Given this list of marker genes DEDD, MYH10, RGR, MLN, SFRP4, FERMT2, POLR3F, CAMK2G, ZNF592, ZNF132, ZNF208, HES2, BBIP1, H1-4, ADAM12, SPAM1, HABP4, ERICH1, H6PD, IL18RAP, AOC2, SOX9, CASP2, MYL5, SELP, LPAL2, HSD17B3, VPS9D1, HPD, MIA, C4BPA, SERPINB13, DNAH17, ADCY2, GPX3, JRK, LTBP4 (latent transforming growth factor beta binding protein 4), OPRPN (opiorphin prepropeptide), LMO2, CHRNE, PXN, LGALS9, POLR3D, OLR1, NR1I2, REG1B, PTGIS, SNAP91 (NCBI Gene Id 9892), CTSA, C9, RNF126, CDK18, SLC1A2, HIPK2, PLA2G4C, PXDN, OCEL1 (NCBI Gene Id 79629), VSTM4 (NCBI Gene Id 196740), GK2, TRIM21, AGRP, KLKB1, AVPR1A, MINAR1, CLCN5, KCNMB1, SGK1, FCN2, FOXO4, TWF1, IFNA2, ZBTB39, N4BP2L2-IT2 (N4BPL2 intronic transcript 2, NCBI Gene Id 116828), MLF1, IRF7, RPE, EPYC, PLPP3, ABCC9, TESK1, CTSO, CRADD, SCGN, SHROOM2, MYO6, PLAAT4, GREB1, PTPRT, GAS2L1, TAF6L (TATA-box binding protein associated factor 6 like), IVL, CCR2, GPM6B, ERN1 (NCBI Gene Id 63433), HR, NTRK3, AKR1D1, GRM3, G6PC1, IFI30, MYEF2, SLC10A2, RS1, GRK1, TNKS, PPFIBP2, PDPK1, DLEC1, PC, KLK8, BRINP3 (BMP/retinoic acid inducible neural specific 3), KRT1, PTH, PXDC1, MAN1A1, CHD2, MUC1, GFPT2, ZNF24, SIN3B, HDAC9, P2RX3, HAAO, PFKFB2, PCSK2, PYGM, ONECUT1, HLA-DQB1, LMO4, GDF5, FZD9, PKP2, ERVW-1, IFIT1, TSC22D1, AMIGO2, TNP2, HLA-DRB6, KCNAB1, NFKBIL1, TCL1A, CYP3A5, MUC7, ZFHX3, CCIN, SPOCK1, FAM161A, SLC1A7, PDE6A, KANK1, PTH2R, S100A9, INHBA, CTRC, FCGR3A, SLC6A9, ATP4A, SYP, EML1, GPR176, TMED1, KLK7, CYP2C19, MTCL2, PLCE1, RFX5, REN, DDO (NCBI Gene Id 8528), CEP162, ATP6V1G2, COL13A1, PROX1, TROAP, H2AC6, SENP3, CCL13, SIM1, AGXT, CSN2, ERC2-IT1, TCTA, ZBTB22, MOG (NCBI Gene Id 4340), KCNJ6, PSG11, ALOX12, KCNMA1, CITED1, MEF2C, ARHGAP22, LINC00667, PRRC1, FBLN1, MGAT5, ALOX12B, AREG, here is a description of the gene set: Human Gene Set: GSE26559_TCF1_KO_VS_WT_LIN_NEG_CELL_DN species: Homo sapiens Tcf1 is necessary for optimal T lineage development. Tcf1 deficient progenitors fail to initiate the T lineage program in vitro and development is severely defective in vivo. We used microarrays to assess the overal global gene expression differences from Tcf1 wildtype and deficient lymphoid biased progenitors cultures on Notch-ligand expressing stroma to determine if Tcf1 deficient progenitors are able to intiate the T lineage specification program. Abstract of manuscript: The thymus imposes the T cell fate on incoming multipotent progenitors, but the molecular mechanisms are poorly understood. We show that transcription factor Tcf1 initiates T-lineage-specific gene expression. Tcf1 is downstream of Notch1 signaling and expressed in early T-cell progenitors. Progenitors deficient for Tcf1 are unable to initiate normal T-lineage specification. Conversely, ectopic expression of Tcf1 in hematopoietic progenitors is sufficient to induce expression of T-lineage specific genes in vitro. Thus, our study identifies Tcf1 as critically involved in the establishment T cell identity. Genes down-regulated in lin- cells: TCF7 knockout versus wildtype. from publication Weber BN, Chi AW, Chavez A, Yashiro-Ohtani Y, Yang Q, Shestova O, Bhandoola A (PMID 21814277)